Given this list of marker genes CEACAM6, DGKG, LAMA5 (NCBI Gene Id 3911), CD19, MARCHF1, ORAI2, LRRC14, ECI1, ENTPD1, ATP2A1, GPT, UGCG, RPL5, FMOD, CCDC88A, HNRNPR, ABCC8, INPP5F, DNMBP, TELO2, TCF4, PPFIBP1, ATP6V0A1 (NCBI Gene Id 535), HLA-DMA, QRSL1, DMAC2L, EPS8L2, ZSCAN9, FAM3C, EHD3, LIN7B, SLC23A2, CHST10, DCTPP1, FCRL2, TBC1D9 (TBC1 domain family member 9), STAP1, HLA-F-AS1, NME1, TPD52L2, TFEB, USP13, IL7, CES1, ATOX1, CD24, SHMT2, AHCY, CD79A, PKIG, BACE2, ISG20L2, ARHGAP22, SELP, TOR3A, KCNN4, AKT2, UGT8, OAZ2, TESC, CD79B, DFFA, DBI, KRT14, AGPAT5, SKP1, RUBCNL, YBX3, NIP7, PDAP1, IGFBP4, PNOC, ARHGDIG, CLMN, SH3BP5, UBE2D4 (NCBI Gene Id 82030), GM2A (NCBI Gene Id 2760), GLO1, SYT17, SNRNP25, MRPL40, SMARCB1, MYO1E, COL9A2, RNF41, DDOST, CBFA2T3, KIF1A, SOBP, RING1, DOK3, LTB, CLIC1, CD40, ABCB4, MAPRE3, EFCAB2, PRMT1, CD2BP2, TCTA, NENF, SETBP1, POU2AF1, TMT1A, H4C7, ENPP2, DAG1, PRKCB, CDK14, BLNK, RPL15, GGA2, SPIB, HLA-DMB, TUBA3D, GPR68, CNPY3, KAT5, IGSF3, FCGR2B, VOPP1, GFOD1, PAX5, SIPA1L3, PDIA3, PHACTR1, ALOX5, WNT16, CPEB1, MEF2C, FAM53B (family with sequence similarity 53 member B), TCTN1, HNRNPF, CSH2, STX7, KRT10, TRAK1, YPEL1 (NCBI Gene Id 94021), TCF3, PI4KB, ARL2, ABCA6, FCGR2C, CD70, RASGRP3, RALGPS2, MIIP, DOP1B, EIF3I, HEMK1, ERP29, CKAP4, BMPR2, ARPC1B, FBXO31, SYNGR2, FCER2, RETREG3, SLC2A1, IRF8, SFMBT1 (NCBI Gene Id 51460), ALX4, GSTT1, BST2, TOP6BL (TOP6B like initiator of meiotic double strand breaks), CD200, GRB2 (growth factor receptor bound protein 2), CREB3L2, BCL11A, RACK1, UQCRH, APOC2, LAMTOR2, GNA12, GATM, SPATS2L, RHOBTB2, CD72, PLIN3, DDAH2, TBC1D22A, COPS6, NCF1C, TMED9, TCL1A, CSNK1G1, MTHFS, PTPN2, LAMB3, CDC42SE1, TPD52, SNX15, OSBPL10, TMED1, MYDGF, TREML2, EEF1G, NHP2, ZNF430, here is a description of the gene set: Human Gene Set: GSE45881_CXCR6HI_VS_CXCR1LO_COLONIC_LAMINA_PROPRIA_DN To identify the role of chemokine receptor in inflammation of colon, we isolated CD3+CD4+ helper T cells harboring CXCR6 from colonic lamina propria of mice We used microarrays to identify the differentially expressed genes between CXCR6Hi Tcells and CXCR6Lo Tcells from publication Mandai Y, Takahashi D, Hase K, Obata Y, Furusawa Y, Ebisawa M, Nakagawa T, Sato T, Katsuno T, Saito Y, Shimaoka T, Yokosuka O, Yokote K, Ohno H (PMID 23840334) species: Homo sapiens Genes down-regulated in colonic lamina propria cells sorted by CXCR6: high versus low.